Given this list of marker genes EIF5, EIF3F, EIF3H, EIF3M, EIF3G, EIF3CL, EIF3C, EIF3E, EIF3D, EIF3B, EIF3I, EIF3K, EIF3J, EIF3L, EIF3A, here is a description of the gene set: species: Homo sapiens Human Gene Set: GOBP_FORMATION_OF_CYTOPLASMIC_TRANSLATION_INITIATION_COMPLEX Joining of the large ribosomal subunit with the translation preinitiation complex, with release of IF2/eIF2 and IF3/eIF3 or IF5B/eIF5B. This leaves the functional ribosome at the AUG, with the methionyl/formyl-methionyl-tRNA positioned at the P site.